Given this list of marker genes Stx6, Vti1a, Vamp4, Stx12, Stx7, here is a description of the gene set: species: Mus musculus Fusion of a synaptic vesicle with an endosome. Mouse Gene Set: GOBP_SYNAPTIC_VESICLE_TO_ENDOSOME_FUSION